Given this list of marker genes RORB, IHH, TTC8, POU4F2, ARL6, SLC1A1, HCN1, PTPRM, TGIF2, ROM1, DIO3, SDK1, CALB1, THY1, ATP2B4, SLC17A8 (NCBI Gene Id 64944), USH1C, RS1, DLX2, ATP8A2, SLC17A7, VSX1, GNAT1, NDP, BARHL2, NOTCH1, ACTL6A, TGIF1, STAT3 (NCBI Gene Id 6774), MEGF11, AHI1, TSPAN12, CASP2, CRB2, CABP4, TGFB2, RP1, SAMD11, VSX2, LARGE1, SAMD7, USP45, THRB (NCBI Gene Id 7068), DLX1, RPGRIP1L, RPE65, HES1, SOX8, PRDM1, BBS4, DLL4, SIX3, HIPK1, PROM1, SMARCA4, RDH13, FAT3, BBS10, BSG (basigin (Ok blood group)), TFAP2B, CRB1, DSCAM, NRL, FOS, ATOH7, LHX1, FJX1, NEUROD1, NAGLU, SDK2, TFAP2A, PDE6C, RAB11FIP4, NTRK2, SMARCD3, ZHX2, GDF11, GNAT2, NEUROD4, RHO, FOXN4, RPGRIP1, PSEN1, PER2, SOX9 (NCBI Gene Id 6662), PTF1A, IRX5, CNTF, GPM6A, HIPK2, here is a description of the gene set: The progression of the neural retina over time from its initial formation to the mature structure. The neural retina is the part of the retina that contains neurons and photoreceptor cells. studied in species Homo sapiens Human Gene Set: GOBP_NEURAL_RETINA_DEVELOPMENT